Given this list of marker genes SCUBE3, CD69, ZNF862, SAR1B, WDR20, SALL3, PIK3CB, ACSL1, ANKIB1, DENND4C, CCDC6, PMEPA1, INO80, BRWD1 (bromodomain and WD repeat domain containing 1), YTHDF2, ITPR1, DENND10, VGLL4, PRKAA2, G3BP2, GADD45A, SPEN, EBF3, NPEPL1, TSC1, ESR1, VPS13D, TSHZ1, JMY, RO60, DDX6, RASD1, CENPO, RUNX3, ABCC5, BMPR2, DLC1 (NCBI Gene Id 94517), SHANK2, LRP12, SMOC1, UBE3B, CD2AP, PSAP, FAT3 (NCBI Gene Id 440062), PSD, TNRC6C, CBX6, BTF3L4, MSMO1, DYNLL2, TLCD3A, RAB12, FYN, MPHOSPH9, PIK3C2A, LDLRAD4, LGALSL, SATB2, TANC2, ARHGAP12, MAPK1, ZMAT3, ARHGAP21, LDAF1 (NCBI Gene Id 57366), PAK6, ZNF800, FSD1L, NRBF2, MMGT1, MECP2, BTBD7, BTBD3, CCDC126, PIP4P2, DLG5, NFIA, GTF2H1, SYT6, RTCA, EPC2, RBBP8, CHD5, MIGA1, DNAJC16, SPHK2, MAF, RAI2, PIGA, SFMBT1, PLCB1, ATG16L1, FOSL1, SBNO1, TES, FBXO28, ZBTB20, TAFA1, DPYSL2, SAMD8, BHLHE41, EPS15, RAB9B, ASXL2, PURG (purine rich element binding protein G), ACBD3 (NCBI Gene Id 64746), RRAGD, MTCL1, TRPC3, DSG1, NABP1, RTN1, DGKE, MFSD6, CNOT6, FERMT2, TMEM50B, WDR33, POP7, DCUN1D3, RAPGEF4, USP13, CBLB, SIX4, HCFC2, THSD7A, SLMAP, HEG1, POU3F2, CNOT4, MBD2, SNX5, ARAP2, SLC44A1 (NCBI Gene Id 63942), PEX5L, AGO1, IRF1, AKIRIN2, INSIG1, PHACTR2, TOGARAM1, SERINC3, PLAA, FSTL5, IGF1, PIKFYVE, ZFYVE26, MBNL1, MAP3K20, OSBPL6, PDZD11, RAB5A, FMR1, FRZB, RBM25, BRWD3, LRP6, OTUD3, C2orf15, IL15, ST18, PPFIA2, SERBP1, ABCB7, ST8SIA5, SMARCD2, AGO4, TET3, CBY1, NCKAP5, AKAP11, NALF1, PHF14, TFCP2L1, PTP4A1, RNF38, CRACD, IL1RAP, PHF12, NHLH2, USP8, SH3D19, THOP1, KLF7, HIVEP2, FUT9, MACIR, RAP2C (NCBI Gene Id 57826), BTAF1, SPART, ZEB2 (zinc finger E-box binding homeobox 2), DNAL1, DCBLD2, GAREM1, WEE1 (WEE1 G2 checkpoint kinase), SRSF2, ATP6V1B2, STON2, IMPDH1, EOGT, LRP2, DEPDC1, KCNA4, SMAP1, ING2, MID1IP1, MDM4, ARL6IP1, PHAF1, PTPN4, ATP12A, EMX2, EIF4E2, ZBTB18, ITGB8, UBXN2B (UBX domain protein 2B), ZBTB4, KIF13A, HECW2, SLAIN1, TEX2, ERCC4, ACBD5, CUL3, ADAM12, PDIK1L, CBFB, ACSL4, STIM2, LRP8, CSMD1, LDLR, SEL1L3, CPEB3 (cytoplasmic polyadenylation element binding protein 3), HOXD1, AAK1, SLC6A6, NSD3, SYBU, CIT, NEUROG1, RAD51B, LPGAT1, WNK1, UBA3 (NCBI Gene Id 9039), NPAT, PRKAA1, RACGAP1, CLTC, LMLN, ADCY1, DYNC1LI2, TGFBR1, MB21D2, AR, CYP2U1, SOS2, MDFIC, CNOT7, MIER1, NPNT, USP28, SBF2, ZNF217, ELK3 (NCBI Gene Id 2004), UBE2D2, SOCS5, EDN1, EGLN3 (egl-9 family hypoxia inducible factor 3), TMEM250, KIAA1191, DAAM1, ABHD3, ENPP5, SECISBP2L, MAP3K12, WDFY3, DOCK3, KRTAP26-1, PGM2L1, ERP44, CAPRIN2, R3HDM1, FIBIN, ULK2, ABCE1, CYSLTR1, LRRTM2, FMC1, CEP170, SNX2 (NCBI Gene Id 6643), CLIP1, HSPA8, MYBL1, ROBO2, DLL1, CLCN3, NFIB, MET, ACVR1, LONRF3, CASD1, LY75, CFL2, PAN3, HS3ST5, PPP6R2, MTMR10, ARHGEF26, ZFYVE9, ZNF107, MIGA2, PTPRG, MEMO1, EREG, CAMSAP2, SNX31, RNF145, CHST1, ERBIN, PPARG, RAB30, SLC2A4RG, STX6, FASTK (NCBI Gene Id 80166), BLCAP, RALGPS2, ABRAXAS2, TRIM2, MLLT6, CLCN5, KDM2A, VCF1, APPL1, ZNF594, BAHD1, RNF216, NECTIN3, KMT2C, NACC2, MBNL3, PPP1R15B, CGGBP1, VPS37A, JARID2, RFX7, FRMD6, ARHGAP1, DCAF8, G0S2 (NCBI Gene Id 50486), LSMEM1, FOXF2, AKAP1, HPRT1, SULF1, UBB, TENT2, BAG5, SPTY2D1, ATG14, KBTBD8, USP33, LCORL, CALM2, SKIDA1, DIAPH3, CDK19, CDS1, FZD6, RPS6KA5, TGFBR2, HOXA3, BMP3, FBXO48, APCDD1, CCNY, TMOD1, SAMTOR, PHF20, LRIG1, TBL1XR1, PRUNE2, JADE1, BTG1, CPEB1, POU4F1, WDR47, PCNX1, HECA, BPTF, AGFG1, GJA1, SZRD1, YY1, SPATA2, DICER1, ITPRIPL2, SNIP1, PRKD3, DSEL, ZNF609, ARHGEF4, UBE2W, PXK, SPOCK1, here is a description of the gene set: from publication Chen Y, Wang X (PMID 31504780) Human Gene Set: MIR130B_3P species: Homo sapiens Genes predicted to be targets of miRBase v22 microRNA hsa-miR-130b-3p in miRDB v6.0 with MirTarget v4 prediction scores > 80 (high confidence targets).